Given this list of marker genes Brip1, Hmces, Tex264, Fam111a, Traip, Vcp, Sprtn, Vcpip1, here is a description of the gene set: The removal of covalent cross-link between DNA and a protein. Mouse Gene Set: GOBP_PROTEIN_DNA_COVALENT_CROSS_LINKING_REPAIR species: Mus musculus